The following is a description of a gene set: species: Homo sapiens Human Gene Set: GOBP_CELLULAR_RESPONSE_TO_ETHANOL Any process that results in a change in state or activity of a cell (in terms of movement, secretion, enzyme production, gene expression, etc.) as a result of an ethanol stimulus., and this is the list of marker genes: ITPR2, CYBB, SOD2, SPI1, GLRA2, RPS6, CCL7, PRKCE, PRKAA1, DRD2, GLRA1, ADCY7, DNMT3A, TP53INP1, SLC23A2